Given this list of marker genes Stub1, Adrb2, Ptger4, Adora2b, Adra2a, Adra2c (NCBI Gene Id 11553), Dock4, Irag1, Dock5, Sod1, Calcrl, Rgs2, Adrb1, Gucy1a1, Kcnma1, Calca (calcitonin/calcitonin-related polypeptide, alpha), Ptgs2, Prkg1, Arhgap42, here is a description of the gene set: Mouse Gene Set: GOBP_NEGATIVE_REGULATION_OF_SMOOTH_MUSCLE_CONTRACTION studied in species Mus musculus Any process that stops, prevents, or reduces the frequency, rate or extent of smooth muscle contraction.